Given this list of marker genes Palm, Actb, Hpca, Myo6, Calr, Rest, Gnat1, Grm1, Neurod2, Slc9a1, Pten, Adss2, Nsmf, Ciita, here is a description of the gene set: Any process that results in a change in state or activity of a cell (in terms of movement, secretion, enzyme production, gene expression, etc.) as a result of an electrical stimulus. Mouse Gene Set: GOBP_CELLULAR_RESPONSE_TO_ELECTRICAL_STIMULUS studied in species Mus musculus